The following is a description of a gene set: Alpha-defensins studied in species Mus musculus Mouse Gene Set: REACTOME_ALPHA_DEFENSINS, and this is the list of marker genes: Defa29, Defa17, Defa43, Defa36, Defa37, Defa5, Prss1, Defa23, Cd4, Prss1l, Defa39, Defa30, Try4, Prss3, AY761185, Defa31, Defa34, Defa26, Defa27, Defa21, Defa40, Defa22, Defa38, Art1, Prss3l, Defa41, Defa35, Defa25, Defa24, Try10, Defa2, Defa42, Defa28 (defensin, alpha, 28), Try5, Prss2, Defa32, Defa3, Defa20